The following is a description of a gene set: studied in species Mus musculus The process of inhibiting aggregation and assisting in the covalent and noncovalent assembly of single chain polypeptides or multisubunit complexes into the correct tertiary structure that is dependent on interaction with a chaperone. Mouse Gene Set: GOBP_CHAPERONE_MEDIATED_PROTEIN_FOLDING, and this is the list of marker genes: Fkbp2, Pdcd5, Ppib, Hspe1-rs1, Ppid, H2-DMb2, Tcp1, Dnajb5, Dnajb4, H2-DMa, Dnajb14, Hspa1b, Hspa5, Pex19, Dffa, Cct5, Dnajb1, Sdf2, St13, Unc45a, Fkbp4, Cct6a, Dnajb8, Hspb1, Ptges3-ps (prostaglandin E synthase 3, pseudogene), Bag1, Hsph1, Hspe1, Clu, Sdf2l1, Dnajb3, Hspa13, Sgta, Umod, Hspb6, Unc45b, Hspa8, Cct7, Fkbp5, Tor2a, Pdcl3, Dnajc5, Tor1a, Dnajb7, Pdcd5-ps, Pdia4, Dnajb13, Dnajb2, Hspa1l, Hspa1a, Dnajc7, Cct8, Dnajb12, Dnajc18, Crtap, Ptges3, Cct3, Hspa2, H2-DMb1, Hspa14, Hspa9, Fkbp11, Chordc1, Dnajb6, Cct4, Hsp90ab1 (heat shock protein 90 alpha (cytosolic), class B member 1), Cd74, Ero1a, Tor1b (NCBI Gene Id 70214), Cct2